The following is a description of a gene set: studied in species Mus musculus Any process that modulates the rate, frequency or extent of extracellular matrix disassembly. Extracellular matrix disassembly is a process that results in the breakdown of the extracellular matrix. Mouse Gene Set: GOBP_REGULATION_OF_EXTRACELLULAR_MATRIX_DISASSEMBLY, and this is the list of marker genes: Fgfr4, Fscn1, Sema5a, Tgfb2, Clasp2, Ddr1, Cst3, Carmil2, Pdpn, Ddr2, Meltf, Clasp1, Ets1, Dpp4, Il6, Fap